Given this list of marker genes CD81, TYROBP, ADAM9, DCSTAMP, TREM2, OCSTAMP, here is a description of the gene set: Human Gene Set: GOBP_MACROPHAGE_FUSION The binding and fusion of a macrophage to one or more other cells to form a multinucleated cell. species: Homo sapiens